The following is a description of a gene set: Pathway Definition from KEGG: APP* -> Abeta -> NMDAR -> Ca2+ -- MCU -> Ca2+(mito) -- MPTP -> CYCS Mutation-caused aberrant Abeta to transport of calcium. Pathway ID: N01003. Pathway type: Variant. Pathway class: nt06460 Alzheimer disease. species: Homo sapiens Human Gene Set: KEGG_MEDICUS_VARIANT_MUTATION_CAUSED_ABERRANT_ABETA_TO_TRANSPORT_OF_CALCIUM, and this is the list of marker genes: GRIN2A, GRIN2B, APP, GRIN1, SLC25A4, GRIN2C, SLC25A31, VDAC2, SLC25A5, MCU (NCBI Gene Id 90550), VDAC3, VDAC1, GRIN2D, CYCS, SLC25A6